The following is a description of a gene set: species: Homo sapiens Human Gene Set: MIR3188 Genes predicted to be targets of miRBase v22 microRNA hsa-miR-3188 in miRDB v6.0 with MirTarget v4 prediction scores > 80 (high confidence targets). from publication Chen Y, Wang X (PMID 31504780), and this is the list of marker genes: SLC14A2, PPP2CA, RICTOR, CHP1, FBXO45, TMEM86A, HECTD1, OSBPL3, SERTM1, CFAP300, GSTM4, PCDHGA12, UBE2I, CXCL9, LUZP1, FNDC5, TNS1, SHISA6, NHSL3, ITCH, SEPTIN4, MNAT1, MEX3D, SLC38A1, USP31, POU2AF2, MAP3K20, CCDC167, ADH5, SLC10A1, PRSS12, SLC1A2, DPYSL3, DVL3, CSKMT, ITM2B, KHDRBS3, CDAN1, COL5A1, GLCCI1, NPEPPS, PAIP2B, RCAN2, GRPR, PCGF3, PRR9, TDRKH, CYP11B1, MIDEAS, OGT, ANLN, NAALAD2, JADE1, SLC26A9, COQ10A, CCDC9B, WDR17, LARP4B, NFATC3, DNAAF5, CLDN12, EDF1, LZTS3, ZBTB39, TDRP, NAV3, PLXNA4, MTCL2, TTC31, NANOS1, CAMK2G, ANGPT4, TMEM150C, ZNF391, CSF3, TTBK2, SPDYA, VWA8, RIGI, ZNF563, ABHD17C, CROT, ARMCX5, CCN2, ZNF317, SRXN1